Given this list of marker genes ACSBG2, HES6, SOX21-AS1, CNKSR3, GAST, TFF3, LINC02089, TPH1, KLK14, KLK12, HTR2C, FAR2P2, LINC02143, KCNH6 (NCBI Gene Id 81033), GHRLOS, POTEI, NUDT16L2P, GPR42, MBOAT4, RFX6, SLC35D3, SEC11C, FFAR2, RPL7AP37, ENTPD8, USP41P, TAS1R3, VWA7, LINC01785, CALCA, LINC00261, LFNG, NPTX1, PRORSD1P, VMAC, PIP4K2C, TENM2-AS1 (NCBI Gene Id 101927862), POTEJ, LINC00390 (NCBI Gene Id 79024), CCNP, ASCL1, PKD2L1, SLC26A5, ACSL1, FAR2P3, here is a description of the gene set: studied in species Homo sapiens Marker genes curated from the annotated cluster as represented in the Descartes Human Gene Expression During Development database. from publication Cao J, O'Day DR, Pliner HA, Kingsley PD, Deng M, Daza RM, Zager MA, Aldinger KA, Blecher-Gonen R, Zhang F, Spielmann M, Palis J, Doherty D, Steemers FJ, Glass IA, Trapnell C, Shendure J (PMID 33184181) The gene expression program underlying the specification of human cell types is of fundamental interest. The study authors generated human cell atlases of gene expression and chromatin accessibility in fetal tissues. For gene expression, the study authors applied three-level combinatorial indexing to >110 samples representing 15 organs, ultimately profiling ~4 million single cells. The study authors leveraged the literature and other atlases to identify and annotate hundreds of cell types and subtypes, both within and across tissues. Our analyses focused on organ-specific specializations of broadly distributed cell types (such as blood, endothelial, and epithelial), sites of fetal erythropoiesis (which notably included the adrenal gland), and integration with mouse developmental atlases (such as conserved specification of blood cells). These data represent a rich resource for the exploration of in vivo human gene expression in diverse tissues and cell types. Human Gene Set: DESCARTES_MAIN_FETAL_NEUROENDOCRINE_CELLS